Given this list of marker genes TOX, H2AC6, H2AC8, H1-2, CBX1, CENPE, H2BC11, TERF2 (NCBI Gene Id 7014), H2AC18, H2AX, MAP2, CENPF, H2BC21, CENPA, H1-0, H2BC13, MAP4 (NCBI Gene Id 4134), HMGB3, H2BC12, HMGB2, MAP7, H2AZ1, here is a description of the gene set: Human Gene Set: MODULE_222 species: Homo sapiens Genes in the cancer module 222.